Given this list of marker genes Igf1r, Dnajc27, Ccl27a, Nob1, Msrb3, Cd9, Ptprg, Egln1, Akr1c6, Cmtm2b, Afap1, Slc35b4, Dzip1l, Cul5, Pars2, Rapgef2, Rbm18, Kcnma1, Egln3, Stk40, Mkx, Wrnip1, Fndc7, Slc30a7, Phactr2, Slc45a3, Unc13c, Ralbp1 (ralA binding protein 1), Fam185a, Nhsl2, Med1, Angptl2, Ythdf1, Zfp597, Plppr1, Hif1a, Klc1, Csnk1g1, Ttc7b, Jazf1, Efna5, Ttc39b, Mb21d2 (NCBI Gene Id 98037), Sertad4, Ostf1, Cflar, Crot, Fsbp, Map4k4, Gpm6b, Pcmtd2, Wnk1, Abraxas2, Ube2g1, Dok1, Gabrq, Fez2, Impact, Cpped1, Chgb, Spty2d1, Defb4, Sft2d3, Marchf2, Slc30a1, Dclk1, Ptp4a1, Yy1, Gigyf2, Rab6b, Snx10, Gpd2, here is a description of the gene set: from publication Chen Y, Wang X (PMID 31504780) Genes predicted to be targets of miRBase v22 microRNA mmu_miR_7022_5p in miRDB v6.0 with MirTarget v4 prediction scores > 80 (high confidence targets). Mouse Gene Set: MIR_7022_5P species: Mus musculus